Given this list of marker genes HES7, RIPPLY2, LETM1, NSD2, PIGG, CPLX1 (complexin 1), FGFRL1, MESP2, CTBP1, NELFA, LFNG (NCBI Gene Id 3955), DLL3, here is a description of the gene set: studied in species Homo sapiens Human Gene Set: HP_RIB_SEGMENTATION_ABNORMALITIES Rib segmentation abnormalities